Given this list of marker genes IPO9, SUDS3, ALDH7A1, TTC9C, FKBP1B, AEBP2, XYLT1, MAPDA, APLP2, COL12A1, HEATR1, UGCG, TRAM2, KLF12, RAP2C, FGF14 (fibroblast growth factor 14), FAM210B, BLZF1, PIGY, NEK9, CDR2, ASAP2, KCNJ2, KHDRBS1, SNRK, TMEM260, COL5A1, HAUS6, ITGA2, CAMK4, NTM, YAE1, CETN3, NEB, RBM48, MBOAT2, CPEB1, MKRN1, RANBP6, TMEM161B, LDLRAD4, KDELR2, ATP9A, EPHA2, NFAT5, DIO2, SH3BP4 (SH3 domain binding protein 4), GLCE, PCDH17, PPARGC1A, OGT, SP110, POLH (NCBI Gene Id 5429), MED13, INO80D, ENDOD1, TAOK3, PLPPR4, ADO, AARD, IL36B, RAE1, WDFY3, LMO7, PAK3, SLC3A2 (NCBI Gene Id 6520), STK31, SEC24A, GEMIN8, APRG1, RTN4, RAB8B, IL13, CCNT2, SIPA1L1, CTBP2, GJC1, BCAT1, FAM234B, HSPA4L, FRMD4A, FCRL4, CPEB2, ZNF354C, AK6, TMEM245, RC3H1, TTC19, THAP11, ZFPM2, ACSL1, here is a description of the gene set: Human Gene Set: MIR4772_3P species: Homo sapiens Genes predicted to be targets of miRBase v22 microRNA hsa-miR-4772-3p in miRDB v6.0 with MirTarget v4 prediction scores > 80 (high confidence targets). from publication Chen Y, Wang X (PMID 31504780)